Given this list of marker genes MAP1LC3A, NCOA4, GAA, HLA-DRB1, RAB30, CLN3, PIK3C3, LAMP2, STX17, FTH1, HLA-DRB3, LAMP1, FTL, SQSTM1, HLA-DRA, RAB39A, LRRK2, PLEKHM1, here is a description of the gene set: Human Gene Set: GOCC_AUTOLYSOSOME species: Homo sapiens A type of secondary lysosome in which a primary lysosome has fused with the outer membrane of an autophagosome or amphisome. It is involved in the second step of autophagy in which it degrades contents with acidic lysosomal hydrolases.